Given this list of marker genes COQ4, COQ2, COQ9, COQ8A, PDSS2, here is a description of the gene set: Human Gene Set: HP_DECREASED_LEVEL_OF_COENZYME_Q10_IN_SKELETAL_MUSCLE Reduced amount of coenzyme Q10,a naturally occurring quinone, in skeletal muscle tissue. species: Homo sapiens Decreased level of coenzyme Q10 in skeletal muscle